The following is a description of a gene set: studied in species Homo sapiens Hypothetical craniofacial development pathway Human Gene Set: WP_HYPOTHETICAL_CRANIOFACIAL_DEVELOPMENT_PATHWAY, and this is the list of marker genes: TGFB3, IRF6 (interferon regulatory factor 6), RHOA, TP63, ARHGEF2, ARHGAP29, TFAP2A